Given this list of marker genes MITF, GNG11, RSPH3, TEDC1, TBC1D22A, ENTPD1, GMEB1, MATK, CYP27B1, SAMD1, EEF1A2, SIX5, FHL3, RHBDF1, NDP, ATP6V0A1 (ATPase H+ transporting V0 subunit a1), TNFRSF8, CLIP2, ACTN1, PPP1R16A, HUS1B, ZNF768, SMPD1, PTGES2, OPA3, TJP2, INSIG1, TGFBRAP1, SLC2A6, MED24, PTGFRN, ZNF264, CES1, NOC4L, TOP3A, TBC1D24, PDGFB, KIAA0930, RASA2, DHCR24, here is a description of the gene set: Human Gene Set: HOFT_CD4_POSITIVE_ALPHA_BETA_MEMORY_T_CELL_BCG_VACCINE_AGE_18_45YO_7DY_UP species: Homo sapiens Genes up-regulated in CD4-positive, alpha-beta memory T cell 7d vs 0d in adults (18-45) after exposure to BCG vaccine, time point 7D, administered PO (oral). Comment: top 100 most significantly altered genes comparing Day 0 and Day 7 responses directly ex vivo Protective efficacy of Bacillus Calmette-Guerin (BCG) may be affected by the methods and routes of vaccine administration. We have studied the safety and immunogenicity of oral (PO) and/or intradermal (ID) administration of BCG in healthy human subjects. No major safety concerns were detected in the 68 healthy adults vaccinated with PO and/or ID BCG. Although both PO and ID BCG could induce systemic Th1 responses capable of IFN-gamma production, ID BCG more strongly induced systemic Th1 responses. In contrast, stronger mucosal responses (TB-specific secretory IgA and bronchoalveolar lavage T cells) were induced by PO BCG vaccination. To generate preliminary data comparing the early gene signatures induced by mucosal and systemic BCG vaccination, CD4<sup>+</sup> memory T cells were isolated from subsets of BCG vaccinated subjects pre- (Day 0) and post-vaccination (Days 7 and 56), rested or stimulated with BCG infected dendritic cells, and then studied by Illumina BeadArray transcriptomal analysis. Notably, distinct gene expression profiles were identified both on Day 7 and Day 56 comparing the PO and ID BCG vaccinated groups by GSEA analysis. Future correlation analyses between specific gene expression patterns and distinct mucosal and systemic immune responses induced will be highly informative for TB vaccine development. from publication Hoft DF, Xia M, Zhang GL, Blazevic A, Tennant J, Kaplan C, Matuschak G, Dube TJ, Hill H, Schlesinger LS, Andersen PL, Brusic V (PMID 28853442)